The following is a description of a gene set: species: Mus musculus Any process that modulates the frequency, rate or extent of protein localization to the cell surface. Mouse Gene Set: GOBP_REGULATION_OF_PROTEIN_LOCALIZATION_TO_CELL_SURFACE, and this is the list of marker genes: Abca2, Abca7, Tor1a, Gopc, Washc1 (NCBI Gene Id 68767), Cdh1, Hnrnpk, Tnf, Ephb2, Nedd4l, Tmem35a, Gpm6b, Cd247, Astn2, Akt1, Tax1bp3, Commd1, Actn2, Map1a, Ctnnb1, Arf6, Lrig2, Tm9sf4, Gbf1, Rab11b, Hsp90ab1, Egf, Hfe, Fcer1g, Stx3, Gpd1l, Erbb4, Rangrf, Stx4a, Synj2bp, Snx33, Ric3 (NCBI Gene Id 320360), Rab11fip5, Picalm, Leprot, Agap2, Kcnab2, Abca12, Tyrobp, Plk2